Given this list of marker genes KYAT1, IL4I1, ASRGL1, PAH, PCBD1, QDPR, here is a description of the gene set: part of: Phenylalanine and tyrosine metabolism The first reaction in this pathway converts phenylalanine to tyrosine, coupled to the conversion of tetrahydrobiopterin to 4a-hydroxytetrahydrobiopterin, catalyzed by phenylalanine hydroxylase. Deficiencies in this enzyme are responsible for the commonest form of phenylketonuria (PKU) in humans. This reaction functions both as the first step in the pathway by which the body disposes of excess phenylalanine, and as a source of the amino acid tyrosine. The next two reactions are responsible for the regeneration of tetrahydrobiopterin from 4a-hydroxytetrahydrobiopterin. Reactome Pathway: Phenylalanine metabolism species: Homo sapiens